The following is a description of a gene set: species: Mus musculus The chemical reactions and pathways involving a long-chain fatty acid. A long-chain fatty acid has an aliphatic tail containing 13 to 22 carbons. Mouse Gene Set: GOBP_LONG_CHAIN_FATTY_ACID_METABOLIC_PROCESS, and this is the list of marker genes: Pla2g4a, Cyp2a5, Cyp2b23, Slc27a2, Myo5a, Acadl, Cthrc1, Cyp2d11 (cytochrome P450, family 2, subfamily d, polypeptide 11), Cyp2g1, Acot4 (NCBI Gene Id 171282), Acsbg1, Acaa1a, Acaa1b, Aloxe3, Cyp2j6 (cytochrome P450, family 2, subfamily j, polypeptide 6), Sphk1, Gstm1, Acad9, Acsl1, Cyp2j12, Abcd3, Cyp4a32, Cyp4f40, Cyp2j7, Gstp-ps (NCBI Gene Id 100042625), Gstp2 (NCBI Gene Id 269054), Elovl6, Cyp2d10, Acot5, Cyp2c55, Pla2g2f, Qki, Acot1 (acyl-CoA thioesterase 1), Cyp2c38, Ptgis, Alox8 (NCBI Gene Id 11688), Alox12, Cyp2d26, Cyp2d9, Cyp1b1, Ephx1, Acsm1, Acox1, Cyp2d12, Cyp2c50, Slc27a1, Gpx4, Fads2, Acsl6, Acsl5, Cyp2j13, Cyp4f18, Cyp4a10, Cyp2a4, Cyp1a2, Ptges, Ptgs1 (prostaglandin-endoperoxide synthase 1), Cyp2j11, Cyp2t4 (NCBI Gene Id 384724), Alox15, Scp2, Gstm3, Cyp1a1, Cyp2c39, Mgll, Cpt1a, Elovl5 (NCBI Gene Id 68801), Pnpla3, Ptges2, Ephx2, Pam, Dagla, Cyp4a12a (cytochrome P450, family 4, subfamily a, polypeptide 12a), Slc27a5, Cyp2u1, Daglb, Ptgr1, Fads1, Asah2, Acot3, Elovl2, Cyp4a30b, Acot2, Tmem135, Lipe, Ahr, Adtrp, Cyp4f15, Mgst3, Plp1, Cyp4a12b, Ptges3, Cyp4a31, Acsl3 (NCBI Gene Id 96921, acyl-CoA synthetase long-chain family member 3), Cyp2d34, Cyp2b19, Cyp2a12, Hacl1, Cyp2s1 (cytochrome P450, family 2, subfamily s, polypeptide 1), Acot9, Alox12b, Slc27a3, Cyp2j9, Acot7, Gstm4, Acot8, Cyp4a14, Cyp2c54, Acsbg2, Cyp2j8, Cyp4f13, Cyp2c23 (NCBI Gene Id 57420), Ptgs2, Cyp4a29, Cyp2c40, Cyp2e1, Cyp2c37, Cyp2b10, Cyp2a22, Cyp2f2, Aig1 (NCBI Gene Id 66253), Acsl4 (acyl-CoA synthetase long-chain family member 4), Cpt2, Gstp3, Ltc4s, Cyp2b9, Ehhadh, Alox12e, Ptgds, Gstm6, Abcd1, Gstm2, Tbxas1 (thromboxane A synthase 1, platelet), Alox5, Slc27a6 (solute carrier family 27 (fatty acid transporter), member 6), Cyp2c29, Cyp4f14, Slc27a4, Sco1, Pnpla8, Cyp2j5, Gpx1, Gstm7, Cyp2d22, Gstp1, Abcd2, Hsd17b4 (hydroxysteroid (17-beta) dehydrogenase 4), Cyp2b13, Acsbg3